The following is a description of a gene set: Human Gene Set: GOBP_CATECHOL_CONTAINING_COMPOUND_CATABOLIC_PROCESS species: Homo sapiens The chemical reactions and pathways resulting in the breakdown of catechol-containing compounds. Catechol is a compound containing a pyrocatechol nucleus or substituent., and this is the list of marker genes: MAOB, SULT1A1, SLC6A3, PDE1B, COMT, MOXD2P, MOXD1, SULT1A4, MAOA, DBH, SULT1A3